Given this list of marker genes IHH, HLX, MIR21, MDK, RC3H2, FOXJ1, FOXP3, CBFB, FGL2, STAT5A, SOCS1, LOXL3, TBX21, PTPN2, RC3H1, SMAD7, PRDX2, IFNB1, LGALS1 (galectin 1), SHH, RUNX1, ASCL2, DTX1, ANXA1, GLI3 (NCBI Gene Id 2737), TNFSF18, JAK3, IRF1, IFNL1, SLC4A2, CLEC4G, BMP4, ZBTB7B, NRARP, BCL6, IL2, RUNX3, ERBB2, TNFSF4 (TNF superfamily member 4), LILRB4, HMGB1, CD74, IFNA2, RAG2, TMEM131L, MIR30B, ZC3H12A, LAG3 (NCBI Gene Id 3902), ZC3H8, CDKN2A, IL4R, CD69, CTLA4, SOCS5, here is a description of the gene set: studied in species Homo sapiens Any process that stops, prevents, or reduces the frequency, rate or extent of T cell differentiation. Human Gene Set: GOBP_NEGATIVE_REGULATION_OF_T_CELL_DIFFERENTIATION